The following is a description of a gene set: Bilateral cryptorchidism species: Homo sapiens Human Gene Set: HP_BILATERAL_CRYPTORCHIDISM Absence of both testes from the scrotum owing to failure of the testis or testes to descend through the inguinal canal to the scrotum., and this is the list of marker genes: ATP6V1E1, KIAA0753, PDE6D, DNAJC19, TMEM216, WDR37, C2CD3, TWIST1, ATP6V1A, TCTN3, CYP17A1, GTF2H5, SRY, IGBP1, NFIX, POLR1A, MEGF8, ASH1L, TOPORS, ZBTB20, CDH11, TMEM231, FARS2, RPL10, RIPK4, PAICS, FGD1, RYR1, COLEC11, FDFT1, NONO, AMH, EP300, KLHL15, LSS, KIF7, POLE, ALX4, AR, MRAP, IFT172, FAM149B1, KAT6A, OFD1, VPS50, ERCC6, AMHR2, MCM5, ODC1, CREBBP, SMARCAL1, COLEC10, CPLANE1, MASP1